Given this list of marker genes CFAP73, TEKT2, DNAAF10, ODAD2, DNAAF1, TTC12, DNAAF4, CCDC40 (NCBI Gene Id 55036), DAW1, CLXN, LRRC61, DRC1, DNAH1, CCDC63, DNAAF2, DNAI4, DNAH8, DNAH7, DNAL1, DNAAF6, DNAAF3, DNAH5, CCDC39, DNAAF8, DNAI3 (NCBI Gene Id 126820), SPAG1, ODAD4, ODAD1, CCDC103, DNAAF11, CFAP100, DNAI2, DNAAF5, DNAI1, ZMYND10, DNAH17, DNAH2, CFAP57, CCDC65, ODAD3, here is a description of the gene set: Human Gene Set: GOBP_AXONEMAL_DYNEIN_COMPLEX_ASSEMBLY The aggregation, arrangement and bonding together of a set of components to form an axonemal dynein complex, a dynein complex found in eukaryotic cilia and flagella, in which the motor domain heads interact with adjacent microtubules to generate a sliding force which is converted to a bending motion. studied in species Homo sapiens